Given this list of marker genes MN1, CHD6, ADAP2, ENTPD4, TRANK1, RUFY3, CCL4, SETD2, ZFYVE16, ZNF568, HOMER1, ZRANB1, SMURF1, RAPH1, ATP8A1, MIA3, NR2C2, RANBP6, ZNF283, FHIP1B, ATOSA, TSC22D2 (TSC22 domain family member 2), LIPT1, PIK3R4, EHD3, VPS13D, ZBTB20, ZDHHC7, MIR101-1, ZNF506, BTG2, ZBTB11, CCSER2, RIMKLB, BTN3A1, WWC2, PIK3R1, TNFSF14, TSPYL2, ZBTB40, FOS, ALK, IL18RAP, KAT6A, CMTM4, FAM234A, LUZP1, LONRF3 (LON peptidase N-terminal domain and ring finger 3), ENSG00000284691, PIK3IP1, SYNJ2BP, SH3BP5-AS1, KLF3, FCHO2, CCNL2, KCTD21, RSC1A1, SOAT1, FCRL3, FTX, TRIM39, ZCCHC14, ZNF805, CTSO, ZNF704, SERTAD1 (NCBI Gene Id 29950), ZBTB10, ZNF284, TRIM52, IL18BP, WDR19, SETD6, VAMP3, BAZ2B, RAB11FIP3 (NCBI Gene Id 9727), KLRK1, CAMK2N1, HECTD4, CRK (CRK proto-oncogene, adaptor protein), NBPF10, WDR35, MPP7, NFAT5, EFCAB14, XCL1, BMPR2, ARID5B, RALGAPA1, KDM7A, C14orf28, CCDC186, CHIC1, HIC2 (NCBI Gene Id 23119), ERO1B, PSME4, TRAPPC10, ITPKC, EPHA4, PDLIM5, PDE4B, BANP, PARP8, RORA, RABGEF1, FAM53B, ZNF239, MGAT4A, POFUT2, MYH3, ZNF559, TULP4, KMT5B, EID3, TEF, TRAF6 (TNF receptor associated factor 6), MAP3K2, TMEM170A, YPEL5, MED13, GPRASP2, EGR2, GCNA, RC3H1, HOOK1, HERC1, ZNF235, SLC30A7, USP33, BICDL1, ZNF33A, ZMAT1, TMCC1, DIPK1A, LEPROTL1, CUX1, POU6F1, OSBPL7, TSC22D1, SYTL2, EEIG1, IL7R, TEX2, CATSPERB, ZHX1, ARAP2, CLIP4, DUSP2, CXCR3, CYTH3, PRDM2, LRRC39, RGMB, BCL2A1 (NCBI Gene Id 597), LINC01138, USF3, FYCO1, DDI2, MYBL1, PHF1, MXD4, WIPF1 (NCBI Gene Id 7456), SPG7, SGK3, AKIRIN1, CHD7, VCPIP1, ZNF91, INTS6L, FAM210B, ZBTB44, ATG14, NR4A3, SMURF2, PIK3CA, CRTAM, DKK3, BTN3A3, UBL3, ASTE1, PPP2R5C, GFPT2, GK5, FOXP1, SNRPN, LLGL2, AGPAT4, ZC3H12A, MAGED2 (NCBI Gene Id 10916), IL4I1, here is a description of the gene set: Triggering of B cell receptors (BCR) induces a massive synthesis of NFATc1 in splenic B cells. By inactivating the Nfatc1 gene and re-expressing NFATc1 we show that NFATc1 levels are critical for the survival of splenic B cells upon BCR stimulation. NFATc1 ablation led to decreased BCR-induced Ca++ flux and proliferation of splenic B cells, increased apoptosis and suppressed germinal centre formation and immunoglobulin class switch by T cell-independent antigens. By controlling IL-10 synthesis in B cells, NFATc1 supported the proliferation and IL-2 synthesis of T cells in vitro and appeared to contribute to the mild clinical course of Experimental Autoimmune Encephalomyelitis in mice bearing NFATc1-/- B cells. These data indicate NFATc1 as a key factor controlling B cell function. from publication Bhattacharyya S, Deb J, Patra AK, Thuy Pham DA, Chen W, Vaeth M, Berberich-Siebelt F, Klein-Hessling S, Lamperti ED, Reifenberg K, Jellusova J, Schweizer A, Nitschke L, Leich E, Rosenwald A, Brunner C, Engelmann S, Bommhardt U, Avots A, Müller MR, Kondo E, Serfling E (PMID 21464221) studied in species Homo sapiens Genes down-regulated in B lymphocytes with NFATC1 knockout: control versus stimulated by anti-IgM for 3h. Human Gene Set: GSE21063_CTRL_VS_ANTI_IGM_STIM_BCELL_NFATC1_KO_3H_DN